The following is a description of a gene set: species: Mus musculus Mouse Gene Set: GOBP_SPLICEOSOMAL_COMPLEX_ASSEMBLY The aggregation, arrangement and bonding together of a spliceosomal complex, a ribonucleoprotein apparatus that catalyzes nuclear mRNA splicing via transesterification reactions., and this is the list of marker genes: Luc7l2, Nol3 (nucleolar protein 3 (apoptosis repressor with CARD domain)), Ddx39b, Ncbp1 (NCBI Gene Id 60346), Gcfc2, Sf3a2, Snrpc, Sfswap, Setx, Mbnl1, Celf5, Luc7l3, Srpk1, U2af2, Crnkl1, Psip1, Celf2, Luc7l, Gemin2, Srsf6, Isy1, Prpf19 (pre-mRNA processing factor 19), Khdc4, Srsf12, Htatsf1, Srpk2, Usp39, Ptbp2, Sf3a1, Celf4, Sf3b1, Scaf11, Srpk3, Ddx42, Sf3a3, Srsf10, Zrsr2, Srsf1, Rbm5, Slu7, Rsrp1, Celf1, Puf60, Gemin6, Ythdc1, Celf3, Ddx46, Celf6, Prpf39, Rbmx